The following is a description of a gene set: Any process that modulates the rate, frequency, or extent of cilium movement, the directed, self-propelled movement of a cilium. species: Homo sapiens Human Gene Set: GOBP_REGULATION_OF_CILIUM_MOVEMENT, and this is the list of marker genes: IRGC, RSPH4A, CCDC39, EPPIN, TAC1, CCDC65, TEX101, DRC1, CCDC40, MKKS, CLXN, TACR2, SEMG2, CFAP206, DNAAF1, TPPP2, TTLL6, PRDM14, BBS4, CCR6, ODAD2, CFAP43, CYB5D1, TAC4, GAS2L2, SEMG1, ADAM7, TAC3, BBS1, KIF9, PGAM4, DNAH11, TACR1, CFAP20, CATSPER1, RNASE10, BBS2 (Bardet-Biedl syndrome 2), CFAP45, CFAP298, TACR3, DEFB1, IQCF1, CFAP69